The following is a description of a gene set: The switching of activated B cells from IgM biosynthesis to biosynthesis of an IgA isotype, accomplished through a recombination process involving an intrachromosomal deletion between switch regions that reside 5' of the IgM and one of the IgA constant region gene segments in the immunoglobulin heavy chain locus. Mouse Gene Set: GOBP_ISOTYPE_SWITCHING_TO_IGA_ISOTYPES studied in species Mus musculus, and this is the list of marker genes: Ccr6, Tnfsf13, BC037156, Nsd2, Msh2, Mlh1, Pms2, Tgfb1